The following is a description of a gene set: Mouse Gene Set: chr9A1 species: Mus musculus, and this is the list of marker genes: Gm7588, Gm24918, Cntn5, Gm6015, Gm7344, Gm32710, Gm7390, Phxr4, Fam76b, Birc3, Gm7495, Gm29785, Mtmr2, Gucy1a2, Or2n2-ps1, Gria4 (NCBI Gene Id 56510), 5330432J10Rik, Casp12, Gm21089, Mmp7, Sesn3, Mmp13, Gm18934, Mmp27, 4930568E12Rik, Alkbh8, Gm24896, Mir101c, Cbx3-ps8, Gm25064, Dync2h1, Kbtbd3, Gm9662, Aasdhppt, Mir1899, Gm5363, Maml2, AV064505, Tmem123, Mmp20, Endod1, Gm22815, Mmp12, Cwf19l2, Birc2, Gm31138, Gm46103, Casp1, 1700019J19Rik (NCBI Gene Id 76412), Jrkl, Gm16485, Mmp1a, Gm10709, 1700128F08Rik, Gm34069, Msantd4, Arhgap42, Gm21070, Yap1, Gm18488, Gm32014, Pdgfd, Ccdc82, Mmp8, Cep57 (centrosomal protein 57), Gm18160, Casp4, Mir6237, Mmp1b, Gm5362, Gm46102, Dcun1d5 (defective in cullin neddylation 1 domain containing 5), Pgr, Gm23097, Cfap300, Mmp10 (matrix metallopeptidase 10), Gm23275, Mmp3, 4930433N12Rik (RIKEN cDNA 4930433N12 gene), Ddi1, Trpc6, Gm47333, Gm7570, Cep126, Gm19324, Gm16833, Mir5618, Gm19212 (predicted gene, 19212), Gm32390, Gm7529